Given this list of marker genes Bgn, Hexa, Hs3st2, Ndst4, Chst13, Gpc3, Ndst2, Hmmr, Sdc4, B3gat3, Abcc5, Hyal2, Csgalnact2, Chst5, Csgalnact1, Ust, Chsy3, Arsb, Prelp, Xylt2, B4galt4, Hs3st6, Kera, Ogn, Chst12, Idua, Hexb, B4galt1, Dcn, Omd, Gns, Chst9, Hs3st5, Slc26a1, Papss1, Uxs1, Hyal3, Hpse, St3gal2, Glb1l3, Chst7, Chp1, B4galt7, Chst2, Sdc3, Slc26a2, Ndst3, Gpc2, Papss2, Fmod, Has2, Naglu, Hgsnat, Cemip, Gpc6, Lyve1, Hs3st3b1, Slc35d2, St3gal6, Agrn, B4gat1, Chst1, Bcan, Dse, Sdc2, Glb1l2, Chpf2, Hyal1, Chst11, Hs3st3a1, Sdc1, St3gal4, Has1, Sgsh, Gusb, Gpc1, Vcan, Chst15, Galns, Lum, Chst3, Gpc4, B4galt5, St3gal3, Glb1l, B3gnt3, B4galt2, B3gnt4, Ext1, Cd44, B3gat2, B3gat1, Chsy1, Hpse2, Slc35b2, Dsel, B3gnt7, Ext2, Hs3st4, Hs6st2, Ids, Hs2st1, Stab2, Cspg4, Slc9a1, Hs3st1, Slc35b3, Chst14, B3galt6, Hs6st1, Chpf, St3gal1, Hs6st3, B3gnt2, Ndst1, Glb1, Acan, Has3, Cspg5, B4galt6, Gpc5, B4galt3, Xylt1, here is a description of the gene set: studied in species Mus musculus Glycosaminoglycan metabolism Mouse Gene Set: REACTOME_GLYCOSAMINOGLYCAN_METABOLISM